The following is a description of a gene set: studied in species Homo sapiens Human Gene Set: HOEK_MYELOID_DENDRITIC_CELL_2011_2012_TIV_ADULT_7DY_DN from publication Hoek KL, Samir P, Howard LM, Niu X, Prasad N, Galassie A, Liu Q, Allos TM, Floyd KA, Guo Y, Shyr Y, Levy SE, Joyce S, Edwards KM, Link AJ (PMID 25706537) Systems biology is an approach to comprehensively study complex interactions within a biological system. Most published systems vaccinology studies have utilized whole blood or peripheral blood mononuclear cells (PBMC) to monitor the immune response after vaccination. Because human blood is comprised of multiple hematopoietic cell types, the potential for masking responses of under-represented cell populations is increased when analyzing whole blood or PBMC. To investigate the contribution of individual cell types to the immune response after vaccination, we established a rapid and efficient method to purify human T and B cells, natural killer (NK) cells, myeloid dendritic cells (mDC), monocytes, and neutrophils from fresh venous blood. Purified cells were fractionated and processed in a single day. RNA-Seq and quantitative shotgun proteomics were performed to determine expression profiles for each cell type prior to and after inactivated seasonal influenza vaccination. Our results show that transcriptomic and proteomic profiles generated from purified immune cells differ significantly from PBMC. Differential expression analysis for each immune cell type also shows unique transcriptomic and proteomic expression profiles as well as changing biological networks at early time points after vaccination. This cell type-specific information provides a more comprehensive approach to monitor vaccine responses. Genes down-regulated in myeloid dendritic cell 7d vs 0d in adults after exposure to 2011-2012 trivalent inactivated vaccine (A/California/7/09 (H1N1), A/Perth /16/2009 (H3N2), B/Brisbane/60/2008), time point 7D. Comment: Down-regulated DE RNA transcripts (down >= 1.5x) shared between both TIV-vaccinated donors, and this is the list of marker genes: DND1, LINC00920, GBP5, PFKFB3, SDC3, NLGN3, SMTNL1, RN7SK, TMEM88